The following is a description of a gene set: studied in species Mus musculus Mouse Gene Set: GOMF_LIGASE_ACTIVITY_FORMING_CARBON_CARBON_BONDS Catalysis of the joining of two molecules via a carbon-carbon bond, with the concomitant hydrolysis of the diphosphate bond in ATP or a similar triphosphate., and this is the list of marker genes: Acaca, Mccc1 (NCBI Gene Id 97117), Mccc2, Pcx, Pcca, Pccb, Acacb